Given this list of marker genes Enpp2, Sat1, Lpin1, Ephx1, Matn4, Cdkn1a, Csrp2, Tob1, Col18a1, Ptprv, Slc66a3, Anxa8, Pltp, Cox6b2, Dgka, Ddit4, Ctsh, Zmat3, Ctsf (NCBI Gene Id 56464), Srxn1, Ly6a, Fas, Robo1, Ivl, Apobec1, Ccng1, Ercc5, Phlda3, Mdm2, Tap1, Pitpnc1, Serpine2, Tnfrsf18, Ak1, Nqo1, Efs, Daxx, Trp53, Fxyd3, here is a description of the gene set: The tumor suppressor protein BRCA1 has been shown to enhance p53 transcription, whereas activated p53 represses BRCA1 transcription. To further understand the functional interaction of these proteins, we investigated the role of BRCA1 in p53-induced phenotypes. We found that BRCA1 when subjected to forced expression acts synergistically with wild-type p53, resulting in irreversible growth arrest, as shown by VhD mouse fibroblast cells expressing a temperature-sensitive mutant of p53. Furthermore, reintroduction of both BRCA1 and p53 into BRCA1(-/-)/p53(-/-) mouse embryonic fibroblasts markedly increased the senescence phenotype compared to that induced by p53 alone. In particular, we found that BRCA1 expression attenuated p53-mediated cell death in response to gamma-irradiation. Moreover, microarray screening of 11 000 murine genes demonstrated that a set of genes upregulated by p53 is enhanced by coexpression of BRCA1 and p53, suggesting that BRCA1 and p53 exert a promoter selectivity leading to a specific phenotype. Taken together, our results provide evidence that BRCA1 is involved in p53-mediated growth suppression rather than apoptosis. Genes up-regulated in MEF cells (embryonic fibroblast) lacking TP53 and BRCA1 by expression of TP53; most genes are further up-regulated by simultaneous expression of BRCA1. studied in species Mus musculus from publication Ongusaha PP, Ouchi T, Kim KT, Nytko E, Kwak JC, Duda RB, Deng CX, Lee SW (PMID 12802282) Mouse Gene Set: ONGUSAHA_TP53_TARGETS